The following is a description of a gene set: Genes down-regulated in comparison of memory CD8 T cells versus naive CD8 T cells. species: Homo sapiens Human Gene Set: GSE32423_MEMORY_VS_NAIVE_CD8_TCELL_DN from publication Ventre E, Brinza L, Schicklin S, Mafille J, Coupet CA, Marçais A, Djebali S, Jubin V, Walzer T, Marvel J (PMID 22942430) Effects of IL-4 on CD8 T cells functions are largely unknown. IL-4 induces survival and proliferation of CD8 T cells, but several studies suggest that IL-4 could also affect several functions of CD8 T cells such as cytotoxicity. Our team has shown that IL-4 repress the expression of Ccl5 in vitro. To define more precisely the impact of IL-4 on CD8 T cells, we performed a whole genome expression microarray analysis of naive and memory CD8 T cells cultured in presence or absence of IL-4. This approach allowed us to define the IL4-gene-expression signature on CD8 T cells., and this is the list of marker genes: LZTFL1, TBL2, MEGF9, TNRC6B, TNFSF11, ARID4A, TLNRD1, CNN3, PRPF3, ZBTB41, ARMCX4, SEH1L, PLAUR, TMEM120B, PLEKHO1, AKTIP, SELENOP, SSR1, DDX6, LANCL2, STAM, TNIK, HCFC2, ZYG11B, POLR1G, NIPAL1, CENPQ, FBXL3, PSD3, ARHGEF11, PTPRF, LIG4, LDHB, ADAR, CUX1, SPATA16, BAZ2B, KCTD9, AP2M1, SOX4, EPHX1, RETREG2, UBE2E2, FAR1, DNAJC6, ELL, GOSR2, EIF2AK3, PMS2, KIF13A, QPCT, BRI3 (brain protein I3), EGR3, PHF8, ITGAE, LRRC47, TSPYL1 (TSPY like 1), GBE1, PTPN11, MPP7, SMNDC1, CCPG1, RB1, SNN, IBTK, NDRG1, ALDH1B1, KPNA3, MGAT2, FAM13B, CLASP2, DESI2, ZBTB33, AGRN, ZNF22, SMARCC2, ATP8A1, F8A1, PPP1R12A, DAPK1 (NCBI Gene Id 1612), CCDC126, DIPK2A, ITM2A, SRRM1, NAA40, DTL, TDRP, BRWD3, GCC1, ANKRD50, RABIF, ABHD13, PAIP1, TP53INP1, GNB4, OTUD1, BASP1, ZHX3, SLC25A47, MTSS1, BRDT, IFT70A, RAPGEF1, TGFBR2, RFWD3 (NCBI Gene Id 55159), TMEM263, ATF1, UCHL1, CERK, TUBB2B, LRRTM4, SIK1, MTURN, FNIP1, PRADC1, APPL1, SMC5 (NCBI Gene Id 23137), MAPDA, ARMCX2, FAM199X, PCMTD2, RAB11FIP4, FBLN2, TIMM29, PFN2, TCF4, FOXC1, SESN1, BEND5, MAGI3, SCAF8, TRAT1, DR1, TSC1, MAGEE1 (MAGE family member E1), XKRX, PPM1L, TCF7L2, IKZF2, ZHX1, TOX, SEPHS2, SLC38A9, SUCLA2, PITPNC1, PRICKLE1, BACH1, GMCL1, NUP153, AP1AR, ZNF451 (zinc finger protein 451), MOB1B, AP3S1, KBTBD7, NANP (N-acetylneuraminic acid phosphatase), SECISBP2L, BCL9, ZCCHC8, MYO18A, MEAF6, FRAT2 (NCBI Gene Id 93368), MGAT5, RBM26, MAP4K4, TM9SF1 (transmembrane 9 superfamily member 1), ALDH2, DSCC1, TWSG1, CHD6, TMEM248, CSNK1E (casein kinase 1 epsilon), TRIM32, ASCC3, TF, YAE1 (NCBI Gene Id 57002), RAB14, KPNA6, CHDH, ZNF251, PLCB4, SSBP3, ARMCX3, KIAA0930, FXYD7, GSN, AMPD1, HACD1, TMEM164, SORCS2, E2F3, ANKRD13D, GPAT3, BRWD1 (bromodomain and WD repeat domain containing 1), TRIM13, LACTB, FADS1, TMEM185A, CTSC, UNG, TDP2